The following is a description of a gene set: Mouse Gene Set: REACTOME_AKT_PHOSPHORYLATES_TARGETS_IN_THE_NUCLEUS species: Mus musculus AKT phosphorylates targets in the nucleus, and this is the list of marker genes: Nr4a1, Foxo4, Akt1, Rps6kb2, Foxo1 (forkhead box O1), Creb1, Akt3, Foxo6, Akt2, Foxo3